Given this list of marker genes SLC1A2, IL26, SLC34A1 (solute carrier family 34 member 1), LRRTM4, JAK1, PHOX2A, SNCG, GSTM2, IRF7, USP25, DOK2, MAEA, LIPE, MLLT1, ASB8 (NCBI Gene Id 79076), FOXO3, ASMT, EEF1G, TRAF1, RCAN3, CELA3A, UIMC1, RFC4, CTRL, TMEM156, EEF1B2, DUSP2 (NCBI Gene Id 1844, dual specificity phosphatase 2), HTR1A, FLOT2, COL14A1, ZNF493, IL18RAP, UBAP2 (NCBI Gene Id 57627), IPCEF1, SZRD1, HSPB2, SP140, WAPL, MCF2, DPY19L2P2, OXLD1, RAD9A, GHSR, CLEC2D, CPSF4 (cleavage and polyadenylation specific factor 4), CD47, ANGPT1, AGTR2, CYP24A1, EVL, GCH1, DLX4, SLCO5A1, CPN2, TMEM134, PAH, ASB4, TAC1, CLIC5, KCNA3, METRN, OR2H1 (olfactory receptor family 2 subfamily H member 1), FURIN, PPP4R3B, DCAF1, FGF12, SPINK5, ARAP2, ANKRD7, PLEKHG3, PYGM, THAP4 (NCBI Gene Id 51078), SEPTIN9, EZH1, LOX, SPOCK2, FGF18, TGFBR3, RPL14, NTAN1, CADPS2, TPH1 (NCBI Gene Id 7166), ZNF211, KIR2DS2, NCKIPSD, CATSPERB, CEMIP, KIR2DS5, LBX1, RSRP1, CREB1, ZNF75D, PIWIL2, GIMAP6, ZNF335, CCL22, PTPN4, SRSF5, ITK, P2RY10, TTLL5, GRM2 (NCBI Gene Id 2912), RPL37A, COQ8A, PTPRCAP, SHBG, PTP4A3, MREG, MAMLD1, RNF44, OPTN, ADAM15, SLC39A9, SH2D1A, SGSM2, PRSS53, SATB1, ADAMTS8, EIF3E, GNAZ, INSL5, ZNF532, GYPB, SIDT1, SERPIND1, ATP9A, MSL3, DLG3, MRPL49, DIDO1, PRKCH, TRPC7 (transient receptor potential cation channel subfamily C member 7), FASN, PRKD2, ARHGEF10L, PDE3A, MED14OS, CRYM, CTAGE9, EPS8L1, OGFOD1, MFAP5, CD48, CX3CR1, PMEL, OMD, SKAP1, SLC35C1, S100A10, PTK2B, KLHL18, ZNF556, FKRP, GOSR2, DLK2, CCND3, ZNF281, NEUROG2, SLC28A3, CYTH1, RHOH, SFI1, PPP3CC, PYHIN1, POLR2C, MAP3K9, POU3F4, ATP4A, MYT1, ETAA1, IRF1, MYO9A, SIM1, PTPRH, ALDH3B2, CYP4B1, IFNG, AZGP1, ACAP1, ARL4C, MTMR12, REM1, AMPD2, NKG7, GARRE1, ZNF276, USP20, HOPX, MYO1C, NSUN5, CLUHP3, GZMH, KCNC4, HOXC4, COL10A1, here is a description of the gene set: Human Gene Set: GSE3982_MAST_CELL_VS_EFF_MEMORY_CD4_TCELL_DN Genes down-regulated in comparison of mast cells versus effector memory CD4 T cells. from publication Jeffrey KL, Brummer T, Rolph MS, Liu SM, Callejas NA, Grumont RJ, Gillieron C, Mackay F, Grey S, Camps M, Rommel C, Gerondakis SD, Mackay CR (PMID 16474395) In the present study we used Affymetrix oligonucleotide microarrays to produce gene transcription profiles for the major leukocyte types in humans. This comprehensive dataset enabled us to not only establish which genes were expressed in each leukocyte type, but also which genes were expressed in each subset after activation. The used of a comprehensive dataset of gene profiles from all the major human leukocyte subsets enabled a novel and powerful means for identification of genes associated with single leukocyte subsets, or different immune paradigms. species: Homo sapiens